Given this list of marker genes KCND2, RPN2, PRPF40A, FA2H, ABRAXAS1, H2BC18, NHLRC2, AMMECR1, GPRIN3, SEM1, PPHLN1, MRPL11, GABRR1, ZSCAN25, HSPA9, RBMS3, CREG1, PDE3A, CDY1, ERCC6, CDKN2B, CDY1B, CDYL, ETNK1, YARS2, WDR26, MTHFD2L (methylenetetrahydrofolate dehydrogenase (NADP+ dependent) 2 like), AHCYL2, RC3H1, MYOC, GRM2, TRIM22, CD44, BCAN, VCPKMT, ABITRAM, NALCN, ZFP3, GPR65, ARL6IP1, ATXN1L, ZC3H13, CCSER2, DISC1 (DISC1 scaffold protein), DTWD2, NOA1, here is a description of the gene set: Human Gene Set: MIR555 Genes predicted to be targets of miRBase v22 microRNA hsa-miR-555 in miRDB v6.0 with MirTarget v4 prediction scores > 80 (high confidence targets). from publication Chen Y, Wang X (PMID 31504780) species: Homo sapiens